The following is a description of a gene set: studied in species Homo sapiens Human Gene Set: GOBP_POSITIVE_REGULATION_OF_INTERLEUKIN_17_PRODUCTION Any process that activates or increases the frequency, rate, or extent of production of any member of the interleukin-17 family of cytokines., and this is the list of marker genes: IL15, ARID5A, IL23A, LY9, IL21, MYD88, TYK2, ZBTB7B, OSM (oncostatin M), RFTN1, IL2, SPHK1, IL6, NOD2, SLAMF6, IL23R, OPA1, SLC7A5, CCL1, JAK2, BTK, PRKCQ, IL18, IL12B, PHB1, TGFB1, NR1H4, CARD9